The following is a description of a gene set: Human Gene Set: HP_ABNORMAL_RESPONSE_TO_INSULIN_TOLERANCE_TEST studied in species Homo sapiens Abnormal response to insulin tolerance test An anomalous response to the insulin tolerance test (ITT), in which insulin is administered intravenously and blood glucose and potentially other compounds are measured at intervals. Insulin administration is intended to induce extreme hypoglycemia (bloodgluoce below 40 mg/dl), which in turn induces release of adrenocorticotropic hormone (ACTH) and growth hormone (GH). ACTH induces the adrenal gland to release cortisol, which together with GH opposes the action of insulin on the blood glucose level., and this is the list of marker genes: STAR, GHRHR, NNT, MC2R, POU1F1, MRAP, TXNRD2, LHX4